Given this list of marker genes IRF8, RAC2, CARD11, WAS, PIK3CG, GATA2, here is a description of the gene set: studied in species Homo sapiens Abnormal decrease of absolute number of monocytes in the blood, per microlitre, compared to a reference range for a given sex and age-group. Decreased total monocyte count Human Gene Set: HP_DECREASED_TOTAL_MONOCYTE_COUNT